Given this list of marker genes MIR9-2HG, MIR133A1HG, MIR302D, MIR184, MIR128-2, MIR643, MIR125A, MIR19B2, MIR124-3, MIR874, MIR30B, DICER1, MIR365A, MIR329-2, MIR148A (microRNA 148a), MIR21 (NCBI Gene Id 406991), MIR132, MIR632, SPACA6-AS1, MIR210, MIR648, MIR539, MIR136, MIR200A, MIR1185-1, MIRLET7C, MIRLET7E, MIR876, MIR146B, MIR197, MIR186, MIR219B, AGO4, MIR580 (microRNA 580), MIR551B, MIR29B2CHG, AGO1, MIR137, MIR10A, MIR147B, MIR640, MIR204, MIRLET7BHG, MIR23A, AGO2, MIR30A, MIR489, MIR7-3, MIR320D1, MIR1197, MIR573, MIR196A2, MIR3142HG (MIR3142 host gene), MIR22, MIR369, MIR124-1, MIR548H2 (microRNA 548h-2), MIR335, MIR206, MIR187, MIR569, MIR302A, MIR99A, AGO3, MIR600, MIR548A3, MIR29C (microRNA 29c), MIR15B, MIR23AHG, MIR504, MIR200C, MIR3065, MIR154 (microRNA 154), MIR103A2, MIR145, MIR129-1, MIR873, MIR122, MIR127, MIR190A, MIR323A, XPO5, MIR656 (microRNA 656), MIR939, MIR30E, MIR621 (NCBI Gene Id 693206), MIR17, MIRLET7A2 (NCBI Gene Id 406882), MIR18A, MIR450A2, MIR3184, MIR101-2, MIR323B, MIR598, DCP2, MIR92A2, MIR1185-2, MIR1180, MEG3, MIR346, MIR16-1, MIR1208, MIR361, MIR103A1, MIR20B, MIR1306, MIR655, MIR199B (microRNA 199b), MIR31, MIR22HG, MIR138-2, MIR551A, MIR425, MIR299, MIR548AJ2, MIR376C, MIR1249, MIR542, MIR590, MIRLET7B, MIR553, MIR320C2 (microRNA 320c-2), MIR30C1, MIR320D2, MIR155, MIR329-1 (microRNA 329-1), SND1, MIR578, MIR24-1, MIR128-1, MIR296, MIR487B, MIR452, MIR1183, MIR330, MIR196A1, MIR25, LIMD1, MIR203B, MIR592, MIR7-2, MIR199A2, MIR20A, MIR19B1, MIR486-1, MIR665, MIR550B2, MIR10B (microRNA 10b), MIR1178, MIR543, MIR92A1, MIR370, MIR501, EIF4E, MIR454, MIR675, MIR138-1, MIR548M, MIR544A, MIR100, MIR9-3, MIR219A1, MIR191 (microRNA 191), MIR98, MIR302C, MIR938, TNRC6A, MIR149, MIR150, MIR134, MIR26A2, MIR135A2, MIR550A1, MIR376A2, MIR548D2, MIR502, MIR770, MIR192, MIR153-1, MIR505, MIR320C1, MIRLET7F2, MIR320B2 (NCBI Gene Id 100313769), MIR548AA2, MIR342, MIR491, MIR144, MIR216A, MIR761, MIR212, MIR499A, MIR424, MIR548H4, MIR548X2, MIR126, MIR889, MIR1207, MIR631, MIR18B, MIR181A2, MIR576, MIR185, MIR199A1, MIR107, MIR486-2, MIR27A, MIR485, MIR577, MIR575, DNM3OS, MIR558, MIR155HG, MIR124-2 (NCBI Gene Id 406908), MIR222, MIR1227, MIR195, MIR326, MIR29B1, MIR140, MIR589 (microRNA 589), MIR1-2, MIR920, MIR3677HG, MIR218-1, MIR626, MIRLET7I, MIR183, MIR26A1, MIR181A1, MIR26B, MIR744, MIRLET7A1, MIR433 (NCBI Gene Id 574034), MIRLET7G, MIR324, MIR450B, MIR548AZ, MIR375, MIR223, MIR409 (microRNA 409), MIR550B1, MIR625 (NCBI Gene Id 693210), MIR198, MIR203A, MIR764, MIR3529, MIR1265, MIR320B1, MIR495, MIR106A, MIR450A1, MIR411, MIR23B, MIR328, MIR338, MIR125B2, MIR196B (microRNA 196b), MIR1912, MIR642A, MIR593 (NCBI Gene Id 693178), MIR1287, MIR1275, MIR612, MIR657, MIR605, MIR302B, MIR3074 (microRNA 3074), MIR601, MIR1237, MIR181B2, MIR377, MIR93, MIR125B1, NEAT1, MIR153-2, MIR103B1, MIR382, MIR217, MIR423, MIR499B, MIR936, MIR581 (microRNA 581), MIR320A, HOXA10-AS (HOXA10 antisense RNA), MIR604, MIR586, MIR142, MIR99B, MIR139, MIR615, MIR636, MIR661, MIR96, MIR181C, MIR1296, MIR137HG (NCBI Gene Id 400765), MIR9-1, PRKRA (protein activator of interferon induced protein kinase EIF2AK2), MIR33B (NCBI Gene Id 693120), MIR103B2, MIR624, MIR497, MIR582, MIR190B, MIR365B, MIR133B, MIR300, MIRLET7F1, MIR30D, MIR221, MIR940, MIR194-2, MIR135A1, MIR541, MIR141, MIR24-2, MIR3120, MIR216B, MIR129-2, MIR609, MIR552, MIR498, MIR496, MIRLET7D, MIR105-1, TARBP2, MIR1307, MIR19A, MIR484, MIR32, MIR487A, MIR642B (microRNA 642b), MIR17HG, MIR711, MIR194-1, MIR607, CARMN, MIR105-2, MIR3591, MIR101-1, MIR500A, MIR211, MIR383, MIR887, MIR922, MIR503, MIR410, MIR30C2, MIR548H3, DHX9, MIR218-2, MIR1827, MIR1253, MIR339, MIR9-2, MIR148B, MIR147A, MIR320E, MIR200B, MIR653, MIR1251, MIR676, MIR7-1, MIR584, MIR362, MIR27B, MIR3179-2, MIR942, MIR214, MIR494, MIR671, MIR133A1, MIR367, MIR224, MIR1-1, MIR448, MIR611, DDX6, MIR618, MIR381, MIR15A, MIR455, MIR331, MIR628, MIR556, MIR133A2, MIR205, MIR550A2, MIR202, MIR490, MIR146A (NCBI Gene Id 406938), MIR488, MIR29B2, MIR33A, MIR135B (microRNA 135b), MIR219A2, MIR500B, MIR934, MIR152, MIR572, MIR29A, MIR944, MIR16-2, MIR376B, MIR345, MIR215, MIR550A3, MIR337, MIR106B, MIR143, MIR877, MIRLET7A3, MIR130A, here is a description of the gene set: Human Gene Set: GOCC_RNAI_EFFECTOR_COMPLEX Any protein complex that mediates the effects of small interfering RNAs on gene expression. Most known examples contain one or more members of the Argonaute family of proteins. species: Homo sapiens